Given this list of marker genes Pcmt1, Csad, Acot11, Hs2st1, Dgat2, Hs3st3b1, Gsta5, Acot3, Elovl3, Tpk1, Acaa2, Galns, Far1, Acsl6, Chst1, Mpst, Slc25a42, Sult2a3, Igf1, Pdk3, Gstm1, Gclm, Extl1, Acss2, Vnn1, Sult3a2, B3galt6, Coasy, B3gat2, Ggt7, Gstp1, Mmaa, Ext2, Hmgcl, Gstm3 (NCBI Gene Id 99537), Slc27a3, Mgst2, Nudt8, Acnat1, Gstt1, Acsl4, Ndst4, Hmgcs1, Acsm4, Nat8, Chst4, Ugdh, Acsm2, Gstt4, Acnat2, Gstt3, Dpep2, Gnmt, Nox1, Extl3, Mtap, Idh1, Sult3a1, Ethe1, Thtpa, Dcakd, Hnf4a, Ces1d, Lias, Arsb, Slc7a11, Hpgds, Btd, Cs, Hmgcs2, Bhmt2, Chst11, Acsl1, Gstm2, Pank3, Chst9, Dgat1, Pmvk, Hexb, Sult2a1 (NCBI Gene Id 20864), Gstp2, Cth, Acacb, Tpst1 (NCBI Gene Id 97280), Chst5, Xylt2, Sult5a1, Cryab, Stat5a, Mpc1, Acss1, Sult1e1, Ogdh, Hs3st1, Gpc1, G6pdx, Bhmt, Sqor (sulfide quinone oxidoreductase), Ctns, Agxt, Ehhadh, Dip2a, Pank1, Snca, Pgk1, G6pd2, Csgalnact1, Pdha1 (NCBI Gene Id 18597), Slc35d2, Hs3st6, Mtrr, Hs6st2, Ahcyl2, Chpf, Elovl5, Mlycd (NCBI Gene Id 56690), Gstm5, Chst7, Pdk1, Suox, Csl, Slc35b3, Sult2b1, Enoph1, Gss, Pxylp1, Dlst, Sult2a5, Abcd1, Ggt6, Mri1, Ctnnb1, Pemt, Gstk1, Crot, Aadat, Slc25a16, Amd1, Mthfd2l, Gsto2, Acot9, Fasn, Elovl4, Gsto1, Acot1, Chpf2, Chst2, Fmo1 (NCBI Gene Id 14261), Mtr, Sult2a6, Acsl5, Pdzd11, Pdk2, Acadsb, Gamt, Mccc2, Hs3st5, Nfe2l1, Chac2, Sucla2, Slc1a2, Mat2a, Nox4, Dpep1, Bpnt2, Hagh, Gsta1, Eif2ak3, Gsr, Gclc, Suclg2, Abcc2, Acat1 (NCBI Gene Id 235373), Gpx1, Sult2a8, Ext1, Enpp1, Cacna1a, Papss1, B4galnt4, Gcdh, Csgalnact2, Pipox, Acaca, Sult1d1, Hsd17b4 (NCBI Gene Id 15488), Sod2, Mgst1, Ghr (growth hormone receptor), Pdha2, Mat2b, Ids, Chst8, Sp1 (trans-acting transcription factor 1), Cbs, Slc19a2, Pank2, Aass, Chsy3, Hs6st3, Slc5a6, Slc19a3, Hmgn5, Acot12, Aaas, Gstm4 (NCBI Gene Id 68555), Tdo2, Oxct2a (3-oxoacid CoA transferase 2A), Sod1, Mettl16, Pax8, Elovl6, Vdac1, Idua, Acsm5, Hpse, Gusb, Ggt5, Ctsl, Suclg1, Chsy1, Dse, B3gat3, Mpc2, Fmo3, Cps1, Slc35d1, Gstp3, Txnrd3, Slc35b2, Ahcyl, Cdo1, Arl6ip5, Htd2, Hlcs, Gpam, Galnt3, Chst3, B3gat1, Mat1a, Cryaa (crystallin, alpha A), Naglu, Elovl7, Mical1, Chac1, Acsm1, Gsta13, Hs3st4, Chst13, Dld, Papss2, Hs3st2, Ndst2 (NCBI Gene Id 17423), Acp3, Chst12, Ndst1, Mvd, Glo1, Acly, Baat, Sult6b2, Lipc (lipase, hepatic), Acot4, Fitm2, Sult2a4, Xylt1, Nudt7, Pter, Alpi, Ndp, Hgsnat, Phgdh, Gstm6, Ndst3, Sult1c1, Gsta4, Hyal4, Oplah, Sult2a2, Hs6st1, Icmt, Hmgcr, Adi1, Acot5, Pdhx, Pdk4, Bckdk (branched chain ketoacid dehydrogenase kinase), Gns, Acot10, Pank4, Gstz1, Sulf2, Mthfr, Bhmt1b, Slc1a1, Mthfd1, Tcf7l2, Gstt2, Cytl1, Tm9sf2, Hs3st3a1, Blmh, Amd2, Acot2, Mmachc (NCBI Gene Id 67096), Tpst2, Elovl1, Far2, Ppcs, B4galnt3, Slc25a19, Acot8, Mmut, Lpo, Sulf1 (NCBI Gene Id 98668), Gsta3 (NCBI Gene Id 14859), Sult1a1, Glce, Hyal1, Acsm3, Abcc1, Mvk, Hnmt, Pdhb, Apip, Arsg, Sult2a7, Comt, Stat5b, Ggt1, Acsl3, Glyat, Gstp-ps, Gsta2, Sult1b1, Gstm7, Mcee, Acot6, Ahcyl1, Nfe2l2, Acot7, Dlat, Sult4a1, Vangl2, Sult1c2, Nudt19, Them5, Sult6b1, Mical2, Gal3st2, Oxsm, Kynu, Ahcy, Ppcdc, Sgsh, Gpat4, Dsel, here is a description of the gene set: Mouse Gene Set: GOBP_SULFUR_COMPOUND_METABOLIC_PROCESS species: Mus musculus The chemical reactions and pathways involving the nonmetallic element sulfur or compounds that contain sulfur, such as the amino acids methionine and cysteine or the tripeptide glutathione.